Given this list of marker genes CRKL, MAPKAP1, RACK1, EIF4EBP1, TYK2, PIK3CD, RPS6KA5, PDCD4, PRMT1, JAK1, SOCS3, MAP2K3, MAP3K1, CREB1, PIAS3, RAP1A, STAT2, MAP2K6, IRF9, GAB2, RPS6KA4, IRS2, RPS6, RAC1, PTPN6, VAV1, MAPK14, PIK3R2, ZAP70, PTPRC, STAT1, FYN, IFNAR2 (interferon alpha and beta receptor subunit 2), MLST8, PTPN11, REL, EIF4A1, RAPGEF1, PIAS1, STAT3, IRS1, SOCS1, STAT4, IFNAR1, CBL, LCK, MTOR, EIF4B, EIF4E, RPS6KB1, PIK3R1, STAT5A, RPTOR, CRK, here is a description of the gene set: studied in species Homo sapiens Human Gene Set: WP_INTERFERON_TYPE_I_SIGNALING Interferon type I signaling